The following is a description of a gene set: studied in species Mus musculus Inner arm structure present on the outer doublet microtubules of ciliary and flagellar axonemes. The structure of inner dynein arms is complex and may vary within the axoneme. Inner dynein arms are heteromeric, comprising 8 different heavy chains and various subunits. Inner and outer dynein arms have different functions in the generation of microtubule-based motility. Mouse Gene Set: GOCC_INNER_DYNEIN_ARM, and this is the list of marker genes: Dnah10, Dnah12, Dnai3, Dnai7, Dnah3, Dnah7a, Dnah1, Dnhd1, Dnah6, Dnah7c, Dnah7b, Dnah2